The following is a description of a gene set: studied in species Homo sapiens Human Gene Set: GOBP_MORPHOGENESIS_OF_A_POLARIZED_EPITHELIUM The morphogenetic process in which the anatomical structures of a polarized epithelium are generated and organized. A polarized epithelium is an epithelium where the epithelial sheet is oriented with respect to the planar axis., and this is the list of marker genes: TTC8, VANGL2, ACTB, WDPCP, CDC42, SH3BP1, YAP1, FUZ, FOXF2, SEC24B, EXOC5, RAB10, DLG5, TP63, CELSR1, INTU, ASTN2, MYO9A, FAT1, NPHP1, SYNE4, JHY, ERBB4, DLG3, AJAP1, WDR1, OPHN1, FZD6, ZDHHC7, SFRP2, WNT9B, PKHD1, AHI1, LAMA1, RAP2A (NCBI Gene Id 5911), IFT20, GRHL3, CAMSAP3, LAMA5, MSN, FOXF1, PAFAH1B1, TCF15, RPGRIP1L (NCBI Gene Id 23322), RHOA, BRSK1, TRAF3IP1, ACTG1, SFRP1, SCRIB, NHERF1, CTHRC1, WNT5A, BRSK2, EZR, FZD3, PTK7, SAPCD2 (NCBI Gene Id 89958)